Given this list of marker genes TRIP6, MLLT11, KANK1, PDXK, SNAI2, NEK6, NRG1, CD44, ITGB5, PTPRE, ITGAV, MT1G, CORO1C, FKBP5, BCKDHA, SEC23A, GSTP1, KLF6, MYC, SOAT1, PROCR, TWSG1, WASF1, AGXT, LRP11, SPATS2L, CTNNAL1, NRP2, BTG3, GLDC, RIN1, S100A10, BBLN (bublin coiled coil protein), ANXA4, CBR1, CBX4, PSMB8, FOXD1, MT1H, ANXA5, DYRK3, LPCAT2, PRNP, MYH9, PHLDA1, FERMT2, APLP2, SERPINB8, FAS, FOSL1, CNN2, ASAP2, ITGA3, ACSL3, PALM2AKAP2, ITGB1, MYO1E, CASP4 (NCBI Gene Id 837), EPHA2, ADORA2B, LRRC8A, FABP5, PXN, ACTN4, ITGA5, DCBLD2, GNG10, SLC1A5, VCL, LRRC8C, EHD4, GBE1, COL18A1, FAM3C, CREG1, PIR (NCBI Gene Id 8544), CLIP4, ALDH7A1, PLP2, SIGLEC7, ACTG2, TAX1BP3, INHBB, YBX3, WLS, IFNGR1, TRDMT1, DEPDC1, ADAM9, SHC1, CBS, FOSL2, ACO1, CAPN2, PLOD1, ZNF106, LDHA, RRAS, SLC16A3, GMEB1, TGFBR2, PTTG1IP, CCND2, EXT1, GCLM, TNFRSF10B, LTBP1, DDX42, CTSC, NRGN (neurogranin), NFIL3, CKAP4, here is a description of the gene set: studied in species Homo sapiens Human Gene Set: MODULE_321 Genes in the cancer module 321.